Given this list of marker genes HSPA13, IRF4, ITGA6, CASP10, BMI1, XBP1, PECAM1, here is a description of the gene set: species: Homo sapiens from publication Zhan F, Tian E, Bumm K, Smith R, Barlogie B, Shaughnessy J Jr (PMID 12393520) To identify genes linked to normal plasma cell (PC) differentiation and to classify multiple myeloma (MM) with respect to the expression patterns of these genes, we analyzed global mRNA expression in CD19-enriched B cells (BCs) from 7 tonsils, CD138-enriched PCs from 11 tonsils, 31 normal bone marrow samples, and 74 MM bone marrow samples using microarrays interrogating genes. Hierarchical clustering analyses with genes clearly segregated the 4 cell types, and chi-square and Wilcoxin rank sum tests (P <.0005) identified 359 and 500 previously defined and novel genes that distinguish tonsil BCs from tonsil PCs (early differentiation genes), and tonsil PCs from bone marrow PCs (late differentiation genes), respectively. MM as a whole was found to have dramatically variable expression of EDGs and LDGs, and one-way analysis of variance (ANOVA) was used to identify the most variable EDGs (vEDGs) and LDGs (v1LDG and v2LDG). Hierarchical cluster analysis with these genes revealed that previously defined MM gene expression subgroups (MM1-MM4) could be linked to one of the 3 normal cell types. Clustering with 30 vEDGs revealed that 13 of 18 MM4 cases clustered with tonsil BCs (P =.000 05), whereas 14 of 15 MM3 cases clustered with tonsil PCs when using 50 v1LDG (P =.000 008), and 14 of 20 MM2 cases clustered with bone marrow PCs when using 50 v2LDG (P =.000 09). MM1 showed no significant linkage with normal cell types studied. Thus, genes whose expression is linked to distinct transitions in late-stage B-cell differentiation can be used to classify MM. B lymphocyte early differentiation genes (EDG): top genes up-regulated in tonsil B lymphocytes (TBC) compared to the tonsil plasma cells (TPC). Human Gene Set: ZHAN_EARLY_DIFFERENTIATION_GENES_UP